The following is a description of a gene set: studied in species Homo sapiens The process of removing one or more phosphate groups from a phosphatidylinositol. Human Gene Set: GOBP_PHOSPHATIDYLINOSITOL_DEPHOSPHORYLATION, and this is the list of marker genes: INPP5K, MTM1, MTMR11, SACM1L, MTMR1, INPP5D, MTMR10, MTMR6 (myotubularin related protein 6), MTMR12, PIP4P1, MTMR3, INPPL1, MTMR2, MTMR9, SYNJ1, PTEN, FIG4, PIP4P2, INPP5E, OCRL, CHRM5, INPP5J, MTMR7, INPP5F, SYNJ2, MTMR4, INPP5A, MTMR8 (myotubularin related protein 8), INPP5B